Given this list of marker genes Dok5, Pcbp1, Ccn4, Bach2, Ncaph, Lysmd4, Shisa2, Macir, Gpm6a, Steap4, Nexmif, Ccdc162, Cstf2, Ints6l, Tgfbr1, Scaf8, Rmnd5a, Xiap, Rlim, Cbx5, Nefh, Kmt2a, Sos2, Nr3c2, Ccne1, Efna5, Slain2, Kmt2e, Polr3e, Zfp106 (NCBI Gene Id 22647), Foxg1, Pola1, Kdm7a, Nr4a2, Spdye4b, Tmem47 (transmembrane protein 47), Rfx3, Tmprss11b, Ggps1, Sowahc, Gabrb3, Kcnd2, Mat2b, Rps6ka6, Dnal1, Barhl2, Gspt2, Pum1, Crebl2, Ahcyl2, Gab1, Satb2, Gemin8, Lilra5, Sppl2a, Chl1, Stox2, Tmf1, Rap1gds1, Armt1, Wdr44 (WD repeat domain 44), here is a description of the gene set: from publication Chen Y, Wang X (PMID 31504780) species: Mus musculus Mouse Gene Set: MIR_216B_3P Genes predicted to be targets of miRBase v22 microRNA mmu_miR_216b_3p in miRDB v6.0 with MirTarget v4 prediction scores > 80 (high confidence targets).